The following is a description of a gene set: from publication Chen Y, Wang X (PMID 31504780) Mouse Gene Set: MIR_1933_3P Genes predicted to be targets of miRBase v22 microRNA mmu_miR_1933_3p in miRDB v6.0 with MirTarget v4 prediction scores > 80 (high confidence targets). species: Mus musculus, and this is the list of marker genes: Sel1l, Cfh, Cep120, Kank1, Cntn2, Dap, Ankle2, Dock1, Cnr2, S100a14, Ythdf3, Mapk1, Rb1, Tbc1d24, Usp42, Rab9b, Nod1, Edar, Foxb1, Cdk8, Luc7l3, Pxdc1, Rps6ka2, Pik3c2g, Spaca7b, Pafah1b2, Pla2g4b, Cd47, Hsd3b1, Sdc3, Zfp316 (zinc finger protein 316), Syn1 (NCBI Gene Id 20964), Rab11a, Gm11780, Wnt1, Tmt1a2, Tmt1a, Slfn8, Gpi1, Tm9sf1, Prkg1, Cfap141, Vamp8, Lrba, Dnaja2